Given this list of marker genes RPA2 (NCBI Gene Id 6118), MRPL18, E2F7, NRP1, UBE2N, HOPX, NUP37, LAMP2, ITSN1, CISD1 (CDGSH iron sulfur domain 1), DCK, TEX15, HPRT1, PPA1, CCDC34, CALM3, NUDT1, PSMD8, MRPL42, DPAGT1, EME1, PSMA5, ORC6 (NCBI Gene Id 23594), AFG3L1P, HIRIP3, RBBP7, TBCB, DUSP5, ALYREF, RAD18, ID2, KLF11, IL1R2, GSAP, SYCE2, COPS4, RGS1, BEX3, SERPINB9, FBXO5 (F-box protein 5), RFC3, IFNGR1, TROAP, PLAC8, PHF11, SERPINE2, TTC9C, GABARAPL1, ALCAM, DAPK2, COMMD3, AKIP1, ANXA4, CD44, PRELID1, UFC1, FKBP2, PMM1, GRB7, DSCC1, IFITM1, BUB3, H4C8, GEM (NCBI Gene Id 2669), TIMM23, NDUFS6, TMED10, TIMM17A, SPDL1, UCK2, GGH, TEX30, YBX3, PRIM2, FAM136A, SNRPA1, LAG3, SNX10, SIVA1, MYL4, ERH, GLRX, NME1, MYADM, CDKN1A, FLNB, NUP43, KIF22, PSMB2, SF3B6, H1-1, LAIR1, ACTG1, AIF1, TMEM163 (NCBI Gene Id 81615), SYPL1, C4orf3, NUP54, NCALD, RAN, DEPDC1, CALM1, POLR3K, SURF4, CDKN2C, SMIM3, APOBEC2, CHST11 (NCBI Gene Id 55807), SYTL3, GCNT1, CRELD2, DLAT, CDK2AP1, ACP1, ZBTB32, ANAPC15, LSM3, RANBP1, CARHSP1, SEPHS2, RBM47, FIGNL1, ANXA1, BSPRY, DBI, AURKA, UBE2S, ACOT7, PSMC3IP, EMP1, CENPP, IL1B, DDOST, FCGRT, CAB39L, TTC39B, RAD51AP1, IRAK3, SAMSN1, ACADL, MXD3, LSM2, TCEAL9, LSM12, CLIC1, HMGN2, TMBIM4, TXNDC17, PSMA1, PANX1 (NCBI Gene Id 24145), SCRN3, TFDP1, IDI1 (NCBI Gene Id 3422), TUBB4B (tubulin beta 4B class IVb), COPS5, SELENOS, PMAIP1, PGAM1, DDX39A (NCBI Gene Id 95781), ERG28 (ergosterol biosynthesis 28 homolog), MPHOSPH6, PBK, CD48, ASF1B, PNP, INSL6, CTLA4, SAR1B, PRF1, NDUFAF2, ETFB, MDH2, VIM, VDAC3 (voltage dependent anion channel 3), CXCL10, CXCR3, MIS18BP1, CD80, TAF12, PYCARD, EPAS1, H2BC4, GPR160, MICOS10, KLRC2, here is a description of the gene set: species: Homo sapiens from publication Parish IA, Rao S, Smyth GK, Juelich T, Denyer GS, Davey GM, Strasser A, Heath WR (PMID 19204323) Peripheral tolerance induction is critical for the maintenance of self-tolerance and can be mediated by immunoregulatory T cells or by direct induction of T cell anergy or deletion. While the molecular processes underlying anergy have been extensively studied, little is known about the molecular basis for peripheral T cell deletion. Here, we determined the gene expression signature of peripheral CD8+ T cells undergoing deletional tolerance, relative to those undergoing immunogenic priming or lymphopenia-induced proliferation. From these data, we report the first detailed molecular signature of cells undergoing deletion. Consistent with defective cytolysis, these cells exhibited deficiencies in granzyme up-regulation. Furthermore, they showed antigen-driven Bcl-2 down-regulation and early up-regulation of the pro-apoptotic protein Bim, consistent with the requirement of this BH3-only protein for peripheral T cell deletion. Bim up-regulation was paralleled by defective IL-7Ra chain re-expression, suggesting that Bim-dependent death may be triggered by loss of IL-7/IL-7R signaling. Finally, we observed parallels in molecular signatures between deletion and anergy suggesting that these tolerance pathways may not be as molecularly distinct as previously surmised. Genes down-regulated in CD8 T cells: undergoing deletional tolerance versus activated. Human Gene Set: GSE14699_DELETIONAL_TOLERANCE_VS_ACTIVATED_CD8_TCELL_DN